The following is a description of a gene set: Human Gene Set: HP_ABNORMAL_THORAX_MORPHOLOGY Abnormal thorax morphology studied in species Homo sapiens Any abnormality of the thorax (the region of the body formed by the sternum, the thoracic vertebrae and the ribs)., and this is the list of marker genes: NFASC, PTDSS1, TOE1, ADAMTS3, GZF1, ZFPM2, ATP6V0A2, HECTD4, CCDC47, CFL2, LMNA (NCBI Gene Id 7816), SH2B1, GDF11, XYLT2, RPL11, TBCK, RREB1, SALL1, KANSL1, COL3A1, NKAP, ZBTB20, FN1, TBC1D24, RPS15A, GORAB, RUNX2, BAG3, SGCB, MEGF10, TUBB3 (NCBI Gene Id 94749), SYT2, PTPN2, LIG4, WNT1, MTOR, WNT7A, BCORL1, IFT172, JAG1, COL5A2, SF3B4, CYP27A1, HSD17B4, CDC42, BUB1B, ACTA1, VWA1, UBE4B, GSC (goosecoid homeobox), PRNP, SLC35D1, PLAA, MPLKIP (NCBI Gene Id 136647), SOX2, SIL1, SRPX2, DDRGK1, TGFB3, DICER1, HBA1, ZEB2, GLI2, LEMD2, MEGF8, RPL35A, TRMT10A, ASPH, DVL1 (NCBI Gene Id 348497), ESAM, RNF113A, FBLN5, DUX4, RNU4ATAC, PPIB, FKBP10, ZC4H2, KBTBD13, RPL27, KRAS, UCHL1 (NCBI Gene Id 7345), BMPR1A, HES7 (NCBI Gene Id 84667), ERCC3, PLCB3, PRKACB, GTF2IRD2, GLE1, ATP2B1, GJA1, CLIP2, CEP152, RPL5, OTUD6B, RRAS, ORC4, POLR2A, PIGQ, GDAP1, PROKR2, DYNC2LI1, ASAH1, ACTA2, SHH, PI4KA, DDX3X, MYOD1, PTEN, SDHD, PIGT, SEMA3E, CYP2R1, PLXND1, ABCA3, AGRN, ARSL, IFT140, KDELR2, TRAF7, CRPPA, ANKRD55, BUD23, GNPTAB, ARFGEF2, KCNJ8, SEC24D, CLCN7, LONP1, CILK1, MATN3, SMS, PDPN, GBA1, KYNU, ANK1, SLC9A6, NSDHL, FLNC, WNT3, HS2ST1, HNRNPH2, FLNA, EVC2, RPS17, LMX1B, SFTPC, NSUN2, CENPJ, MUSK, EXT1, FAM111A, FBN1, PGAP3, MAPRE2 (microtubule associated protein RP/EB family member 2), MET, HIRA, RFC2, ZIC2, ERLIN1, COG1, FUCA1, DNMT3A, ARID1B, ATP7A, BANF1, LIFR, LMBRD2, RAP1B, POR, SEC23A, DPYSL5, MYH11, RSPRY1, ALG12, SHOC2, GDF3, SPTLC1, MYO9A, TENT5A, SLC12A2, CRIPTO (cripto, EGF-CFC family member), STIL, B3GAT3, PPP2R1A, LRRK1, GNE, NF1, PRKG1, KY, CAPN3 (NCBI Gene Id 825), CTSK, TRPV6, MESD, PSMB8, DNM2, MMP23B, NEK9, RIT1, MYL11, GMPPB, BGN, EFL1, CANT1, SYNE2, TGFBR1, MSTO1, KDM6B, DNAJC21, TRPV4, TMEM53, JAG2, TRIP4, WRN, ITGA7, ACAN, GTPBP2, HRAS, KDM5C, PIGS, LOX, BAZ1B, KLHL41, CYP21A2, PEX5, POMT2, VAC14 (VAC14 component of PIKFYVE complex), MTM1, DYNC2H1, PRIM1, SRY (sex determining region Y), SOX5, ANO5, GABRD, MEOX1 (mesenchyme homeobox 1), FOXF1, CHST3, GALNS, IRX5, DYNC2I1, BRD4, PAX7, CBS, KRT5, MAP2K1, LZTR1, THSD4 (thrombospondin type 1 domain containing 4), ODC1, LMOD3, MESP2, MAT2A (NCBI Gene Id 4144), TBCD, SQSTM1, RIPPLY2, TBX3, SEC23B, MMP14, GFPT1, FGD1, ANXA11, MLXIPL, CD247, AP1G1, NAGLU, SUFU, EFEMP2, PUM1 (NCBI Gene Id 9698), RERE (arginine-glutamic acid dipeptide repeats), COL5A1, PTPN22, GABRA3, SV2A, NUP107, CDON, PIGW, PHEX, DYNC2I2, LTBP2, GAS1, ADAMTS10, RAD21, IARS2, CUX1 (cut like homeobox 1), EP300, OPA1, TBX5, ANAPC7, PIGA, ALPL, KIAA0586, FAT4, HBA2, DOK7, ENPP1, CHD7, RMRP, RNU12, TUBB, SMC3, TBCE, MYLK, CHRM3, MEG3, ITGA3, SON, ARSK, PIGG, PAICS, LRP2, TCTN3, XYLT1, LAMA5, GLI3, COL11A2, ARSB, RPS20, PIGY, PTPN11, VPS35L, NFIX, RAF1, SRCAP, MAP1B, PPP1R21, MME, TTC21B, NIPBL, SH3PXD2B, COL11A1, SRP54, AKT1, GNS, CASR, DYM, COG4, CA2, SBDS, EYA1, NEU1, PIGN, EIF2AK3 (eukaryotic translation initiation factor 2 alpha kinase 3), SMPX, CHST14, PTCH1, ACTB, CHAT, CBL, HDAC6, EXT2, MAP2K2, GPKOW, ADNP, GPX4, ANTXR1, RAB33B, RTTN (rotatin), HHAT, RPS29, IFT52, POP1, DYSF, EMD, SIM1, NEDD4L, MYBPC1, RIPK4, B4GALT7, ORC1, CHRNG, DCHS1, SLC2A10, AK9, LRP4, SCUBE3, DNM1L, FGFR3, RPL15, HNRNPK, TGDS, NEPRO, SPEN, NGLY1, TAF6, IFT43, PIGO, PIGL, KIF22, SFRP4, MYPN, EXOC6B, FAM20C, MGAT2, ALDH18A1, H19, RPL8, IFT122, PLOD1, PACS1, MMP13, TGFB2, CUL4B, NRAS, OCRL, SMC1A, ALMS1, ORC6, USF3, ASXL1, SPTAN1, FBXO11, CUL7, ESCO2, MYSM1, VAMP1, MBTPS1, TWIST1, SETBP1, MYH3, PDGFRB, LFNG, NOG, CSPP1, KIF7, STX5, MYF5, PLEKHM1, COLQ, SGCG, TNFSF11, FAM149B1, FRG1, TAF4, RPS7, FREM2, KAT6A, ADA, ZNF668, COL10A1, MSX2, SLC16A2, WDR81, DPF2, RAPSN, BICD2, SOST, NEB, JMJD1C, PIGV, CEP120, SNX10, METTL27, SELENON, SP7, SLC26A2, PPP3CA, ERCC2, CCN6, SMAD2, CD96, TTN, SALL4, KLLN, CHD6, VCP, DNMT3B, FLNB, EZH2, KIAA0753, NADSYN1, ZMPSTE24, RPS26, BIN1 (bridging integrator 1), PCYT1A (NCBI Gene Id 5130), HYOU1, G6PC3, ATAD3A, RPS10, PORCN, MARS2, GLI1, CCDC8, PYCR1, NHLRC2, MMP2, GTF2E2, ADAMTS15, FHL1, TNNT1, MTRFR, USP18, FBN2, KCNAB2, FLI1, DONSON (NCBI Gene Id 55597), DYNLT2B, ERF, MED25, FMR1, WNT4, BRAF, INPPL1, CHST11, DNAJC30, MGP, SPECC1L, AMER1, B4GAT1, GNPTG, COL6A1, MBTPS2, SRD5A3, GDF6, PIK3C2A, FARSB, GNB2, ASH1L, FOXH1, REST, EFNB1, SLC26A1, VPS33A, MOGS, INTS1, TARS1, RYR1, ADAMTSL2, IFT80, PYCR2, ACTG2, ERI1, TMTC3, DES, IL2RB, SMAD4, CRTAP, ARF1, EBF3, CHRNB1, COL1A1 (NCBI Gene Id 4970), KLHL40, DDR2, TK2, CREB3L1, KDM6A, RPL31, PAM16, ABL1, UBA1, MTMR14, TMEM94, NPR2, TGFBR2, PIEZO1, ZDHHC9, RNF135, B3GLCT, SLC25A1, LHX3, HOXD13, TCIRG1, TBL2, RYR3, COMP, DSTYK, GATA1, CDH11 (NCBI Gene Id 1009), TONSL, NSD1, PCNT, SMO, ELN, RPS27, FGFRL1, SYNE1, IGF1R, LGI3, SPRTN, AARS1, COL2A1, IDUA, SGCD (sarcoglycan delta), SNAP25, GATA6, DVL3, IL1RN, TNFRSF11B, CSGALNACT1, WNT5A, WDR19, NARS1, SMARCAL1, TRIO, HDAC8, CTBP1, RBM10, ATR, APC2, RPL26, MYF6, NOTCH2, MAN2B1, SKI, EFEMP1, NALCN, SC5D, HACD1, SCN4A (sodium voltage-gated channel alpha subunit 4), DHCR7, VANGL1, HUWE1, PPP1R15B, KMT2D, NEFL, TWNK, FGF8, CPLX1, GP1BB, SIK3, LAMB2, POLG, TOMM7 (translocase of outer mitochondrial membrane 7), PRKG2, MAX, DPAGT1, PIK3R2 (phosphoinositide-3-kinase regulatory subunit 2), POLR3A (NCBI Gene Id 11128), PLIN4, MRAS, ERMARD, TRIP11, LGI4, SLC5A7, DUX4L1, PIGU, EIF4H, FUZ, PYROXD1, NELFA, DISP1 (dispatched RND transporter family member 1), PRR12, LRP5, CSF1R, TELO2, IFT81, RAB3GAP2, WNK3, UBTF, GUSB, IDS, GPC3, AEBP1, GJA8, ADGRG6, APC, SPRED1, AFF3, EHMT1, FBXL3, PTF1A, ZMIZ1, RBM8A, PTCH2, PGAP2, IDH1, UFD1, MED12L, BCOR, C19orf12, VDR, MAPK1, B3GALT6, ZFX, SLC17A5, STX1A, SLC34A1, HEATR3, NAA10, CTNS (cystinosin, lysosomal cystine transporter), EBP, RET, BICRA, OBSL1, TBX4, ATP6V1B2, CHRNE, GJA5, TMCO1, RRAS2, SOS1, FBXO28, INTU, BMPER, WASHC5, PRKACA, TRAPPC2, SGSH, CDC6, IKBKG, TBX1, RPS28, MFAP5, SPEG, FERMT1, SIX6, PRDM16, CRELD1, IGF2, MECP2, NKX3-2, TPM2, SMCHD1, SLC34A3, RNU4-2, IL2RA, CARS1, ITCH, HNF1B, GNPNAT1, TNPO3, PDHX, PAX1, NODAL (NCBI Gene Id 8114), DLK1, SEC24C, SLC10A7, IL6ST, TBX6, ALG14, AHDC1, GPC4, ALG2 (NCBI Gene Id 85365), MAP3K20, LRIF1, SOX9, SDHB, FGFR1 (fibroblast growth factor receptor 1), HGSNAT, MYL2, LBR, MED12, DSE, KMT2A, RPL9, CASZ1, DYRK1A, LUZP1, NXN, CHD4, SCAF4, FKTN, RIN2, GLB1, WDR35, FILIP1, ABCC6, RTL1, MAMLD1, TPM3, FGFR2, POGLUT1, CHRND, TMEM270, GNB1, ARL3, PRKCZ, VPS37D, CPLANE1, PIK3CA, TOR1A, HINT1, HDAC4, COL6A2, CCBE1, COMT, VPS37A, MBD5, FKBP6, SERPINH1, WBP11, SOS2, OSGEP, ABCC9, EVC, DHCR24, KDM5A, RPL35, ABCD4, IPO8, HNRNPH1, ELMO2, RSPO2, DHODH, CREBBP, NUP88, UPF3B, LYSET, COL12A1, ARVCF, TBX15, FRA10AC1, DMD, PLOD2, DLL3, SLC37A4, ANKRD11, ARID2, C2CD3, FZD2, EMILIN1, UBE3B, FRAS1, FOXE3, NSD2, VPS13B, ALDH1A2, DACT1 (NCBI Gene Id 51339), ALDH3A2, CCDC22, NEK1, MYH2, HPGD, PLK4, SGCA, RASA2, SLC18A3, SCARF2, BMP4, SFTPB, CBFB, LETM1, GTF2H5, ADA2, TBX2, ATG7, PUF60, GTF2I, NOTCH3, MAN1B1, LEMD3, CDT1, TSR2, KCNQ1OT1, KCNJ2, RPS6KA3, RAB5IF, CCN2, TGIF1, GAD1, PUS1, PAX3, WDR11, PIEZO2, PEX1, PPP1CB, SPRED2, HERC1, GATA4, TMEM43, CHRNA1, ACP5, MAP3K7, MAF, IRF6, AGA (aspartylglucosaminidase), RECQL4, LTBP1, GMNN, CYP27B1 (NCBI Gene Id 5135), PTH1R, NCF1, MTX2 (metaxin 2), PQBP1, ROR2, ALX4, SIX3, CFAP410, RBBP8, CDC42BPB, SLC2A1, PHF8 (PHD finger protein 8), BMP1, TRPM3, P4HB, TCTN2, SNRPB, COL13A1, TAPT1 (transmembrane anterior posterior transformation 1), NPR3, HSPG2, AIFM1, SOX10, DLL1 (NCBI Gene Id 28514), RPL18, BMP2, AR, P3H1, SDHC, STAT4, CDC45, IGBP1 (NCBI Gene Id 3476), RPS19, RPS24, TAF1, SF3B2 (splicing factor 3b subunit 2), COL1A2, SNX14, HNRNPR, FIG4, ADGRG1, HEY2, GTF2IRD1, PCGF2, IHH, MYH7, LIMK1, BAP1, EXTL3, SMAD3, TFE3, TRPS1 (NCBI Gene Id 7227), DLG3, GRIP1, CDH2, IFT57 (NCBI Gene Id 55081), GYG1, SEPTIN9, TNFRSF11A, COL6A3